Given this list of marker genes ENSG00000294900, LPA (NCBI Gene Id 654241), PACRG, PACRG-AS1, KRT8P44 (NCBI Gene Id 100129958), PACRG-AS2, MAP3K4-AS1, PRKN, MAP3K4, QKI, ENSG00000231863, PLG, ENSG00000303181 (NCBI Gene Id 105378097), ENSG00000286498, CAHM, AGPAT4, RN7SL366P, PACRG-AS3, here is a description of the gene set: Human Gene Set: chr6q26 species: Homo sapiens